Given this list of marker genes COL4A5, PTGES, PHF20L1, DCX, USP10, EBP, SUZ12, COPG2IT1, MTFR1, HSD11B2, EFNB3 (ephrin B3), ZNF273 (NCBI Gene Id 90816), BRIX1, B4GALT3, MCM2, NUDT9, CLDN15, SLC25A12, RAB3IP, GAPDH, PIGG, ZNF444, FAM167A, ATXN2L, IST1, ANGPTL1, RNF135, FGFBP2, NFE2L3, KIAA0087, RPAIN, DNALI1, UBE4A, PSME4, CCNO, MOBP, HOXD11, NUCB2, KDM7A, BZW1, TBC1D4, SNAP47, MAU2, GPATCH2, USP18, BCLAF1, NAA50, PLEKHM1, FICD, PROM1, WDR36, SFXN3, GUK1, ADGRG6, NMNAT2 (nicotinamide nucleotide adenylyltransferase 2), MAP6, KLHL6, STK17B, TSPAN3, SEC24C (SEC24 homolog C, COPII coat complex component), TRIM35, SAP30L, LSM6, DDX25, PARVA, CUL2, ANKRD11, VIPR1, FADS2, RAN (RAN, member RAS oncogene family), PWP1, SLC16A10, SCN8A, SPCS2, LHB, UFL1, PTP4A3, IPCEF1, VEZT, ARID1A, NET1, FHL3, PPP4R3A, GATAD2A, CINP, TOMM34, COLQ, GYG2, MRPL42, TREM2, MMP17, FOXJ1, POLD3, MBNL1, FCHO2, GRIK1, USP6NL, DENND2D (NCBI Gene Id 79961), PYROXD2, OXCT1, NCL, SFXN2, IQSEC1, PRDX6, POGLUT2, EMC1, HECTD4, HMGCR, CNTN3, EPB42, DNAJC13, TPD52L1, ZNF184, CBX1, HIVEP1, PCLO (piccolo presynaptic cytomatrix protein), MAP3K1 (NCBI Gene Id 4214), NEO1, CNOT2, SYT11, HOXB6, LPIN1, UBE3C, ADAMTS6, NTF3, PRPSAP1, ECM2, ZNF251, RXYLT1, GRAMD1B, ST3GAL6, ATR, REEP1, GPR146 (G protein-coupled receptor 146), CSF1, MBTPS1, RFTN1, NKTR, SEPTIN10P1, DHCR24, TRIO, MS4A6A, MORC3, R3HDM1, ENY2, ANAPC15, PRSS27, CENPU, RABGAP1, TNIP1, HERC3, PAFAH1B2, COCH, SRGAP3, here is a description of the gene set: Genes in the cancer module 206. Human Gene Set: MODULE_206 species: Homo sapiens